The following is a description of a gene set: An integral membrane complex that possesses NADH oxidoreductase activity. The complex is one of the components of the electron transport chain. It catalyzes the transfer of a pair of electrons from NADH to a quinone. species: Homo sapiens Human Gene Set: GOCC_NADH_DEHYDROGENASE_COMPLEX, and this is the list of marker genes: NDUFS7, NDUFB5, NDUFB2 (NCBI Gene Id 4708), NDUFV1, MT-ND4L (mitochondrially encoded NADH:ubiquinone oxidoreductase core subunit 4L), NDUFS8, NDUFAF2, NDUFAB1, NDUFB8, NDUFA4, NDUFA6, MT-ND1, NDUFA8, NDUFS5, NDUFS2, WDR93, MT-ND6, NDUFB7, NDUFB4, NDUFV3, NDUFS1, NDUFB11, MT-ND2, NDUFA2, NDUFA12, NDUFA1, NDUFC2-KCTD14, NDUFA9, NDUFA7, MT-ND5, NDUFB1, NDUFS3, NDUFS4, NDUFV2, MT-ND3, NDUFB6, NDUFA13, NDUFB3, NDUFA5, MT-ND4, NDUFA3, NDUFA11, NDUFC1, NDUFS6, NDUFB10, NDUFC2, NDUFA10, NDUFB9